The following is a description of a gene set: species: Homo sapiens Human Gene Set: GOMF_BIS_5_ADENOSYL_PENTAPHOSPHATASE_ACTIVITY Catalysis of the reaction: P1-P6-bis(5'-adenosyl) pentaphosphate + H2O = AMP + adenosine 5'-tetraphosphate., and this is the list of marker genes: NUDT4, NUDT11, NUDT10, NUDT3, ENPP3, NUDT4B